Given this list of marker genes HAS1, CEMIP, HAS2 (hyaluronan synthase 2), ABCC5, HAS3, here is a description of the gene set: Human Gene Set: REACTOME_HYALURONAN_BIOSYNTHESIS_AND_EXPORT studied in species Homo sapiens Hyaluronan biosynthesis and export